The following is a description of a gene set: Mouse Gene Set: GOBP_CORTICAL_MICROTUBULE_ORGANIZATION studied in species Mus musculus A process that is carried out at the cellular level which results in the assembly, arrangement of constituent parts, or disassembly of structures formed of microtubules and associated proteins in the cell cortex, i.e. just beneath the plasma membrane of a cell., and this is the list of marker genes: Ezr, Pafah1b1, Ppfibp1, Kif21a, Tln1, Dlg1, Trpv4